Given this list of marker genes SIK3, TBK1, OTUD7B, AKT1, OTUD5, EP300, NCKAP1L, USP9X, here is a description of the gene set: Human Gene Set: GOBP_POSITIVE_REGULATION_OF_TORC2_SIGNALING Any process that activates or increases the frequency, rate or extent of TORC2 signaling. studied in species Homo sapiens